The following is a description of a gene set: species: Mus musculus Mouse Gene Set: GOBP_REGULATION_OF_TOLERANCE_INDUCTION Any process that modulates the frequency, rate, or extent of tolerance induction., and this is the list of marker genes: Cd3e, Cblb, Nr5a2, Foxp3, Irak3, Lilrb4b, Lilrb4a, Hmgb1, Ccr7, Phlpp1, Cd86, Marchf7, Tgfbr2, H2-M3, Runx1, Itch, Foxj1, Pdcd1 (programmed cell death 1), Ido1, Havcr2, Il2ra